The following is a description of a gene set: species: Homo sapiens Human Gene Set: HP_KINETIC_TREMOR Kinetic tremor Tremor that occurs during any voluntary movement. It may include visually or non-visually guided movements. Tremor during target directed movement is called intention tremor., and this is the list of marker genes: RARS1, ABHD12, TMEM240, GTF2E2, AKT1 (AKT serine/threonine kinase 1), ATXN10, POLR3A, TMEM63A, CTDP1, PSAP, ATCAY, VLDLR, GJB1, TMEM70, GJC2, KCNK4, HMBS, POU4F1, ARSA (arylsulfatase A), GRIK2, TBP, VWA3B, POLG, NOP56, KNSTRN, FARS2, ATP2B3, TSPOAP1, CACNA1A, CCDC88C, SCP2, TTR, NOTCH2NLC, SPTBN2 (spectrin beta, non-erythrocytic 2), ELOVL4, PIK3CD, TECR, RNU12, ITM2B, UCHL1, TPR, TENM4, ITPR1, SEMA6B, GTF2H5, CSTB, PEX10, WDR81, SPTBN1, PNPLA6, CACNA1C, SACS, SCYL1, FMR1 (NCBI Gene Id 5421), CAMTA1 (calmodulin binding transcription activator 1), NFASC, ERCC3, FBXO7, MRE11, AFG3L2, ATM, ADPRS, ANO10, ERCC8, QRICH1, RFC1, AMACR, EPRS1, POLR3B, PLA2G6, FXN, TGM6, HSD17B4, RNF113A, CARS1, MAOA, NKX2-1, MPLKIP (NCBI Gene Id 136647), SLC25A46, CWF19L1, KIF1C, PIK3CA, SNCA, NONO, TMCO1, PI4KA, OPHN1, ATXN2, PPP1R15B, SCARB2, PPP2R2B, AARS1, TARS1, UFC1, PLP1, ABCB7, HYCC1, PMM2, PRICKLE1, ERCC6 (ERCC excision repair 6, chromatin remodeling factor), XPNPEP3, PTEN, TMEM106B, ERCC2, TPK1, LMAN2L, KCNN2, KCNJ10 (potassium inwardly rectifying channel subfamily J member 10), LMNB1, GSS, SMG9, LEMD2